Given this list of marker genes SFRP1, FOXO1, CTNNB1, DCN, WNT4, SST, SMAD1 (SMAD family member 1), DKK1, BCL2L11, LEFTY2, SMAD5, BMP2, SMAD9, here is a description of the gene set: Human Gene Set: WP_BMP2WNT4FOXO1_PATHWAY_IN_PRIMARY_ENDOMETRIAL_STROMAL_CELL_DIFFERENTIATION BMP2-WNT4-FOXO1 pathway in primary endometrial stromal cell differentiation studied in species Homo sapiens